The following is a description of a gene set: Genes down-regulated in primary endothelial cells (HUVEC) after knockdown of WTAP by RNAi. from publication Horiuchi K, Umetani M, Minami T, Okayama H, Takada S, Yamamoto M, Aburatani H, Reid PC, Housman DE, Hamakubo T, Kodama T (PMID 17088532) Wilms' tumor 1-associating protein (WTAP) has been reported to be a ubiquitously expressed nuclear protein. Although a relation to splicing factors has been postulated, its actual physiological function still remains to be elucidated. To investigate the role of WTAP, we generated WTAP-knockout mice and performed small interfering RNA (siRNA)-mediated knockdown analyses in primary cultured cells. In DNA microarrays using human umbilical vein endothelial cells, WTAP-targeted siRNA treatment resulted in markedly reduced expression of cell-cycle-related genes. siRNA-mediated WTAP knockdown down-regulated the stability of cyclin A2 mRNA through a nine-nucleotide essential sequence in cyclin A2 mRNA 3' UTR. WTAP knockdown induced G2 accumulation, which is partially rescued by adenoviral overexpression of cyclin A2. Moreover, WTAP-null mice exhibited proliferative failure with death resulting at approximately embryonic day 6.5, an etiology almost identical to cyclin A2-null mice. Collectively, these findings establish WTAP as an essential factor for the stabilization of cyclin A2 mRNA, thereby regulating G2/M cell-cycle transition. studied in species Homo sapiens Human Gene Set: HORIUCHI_WTAP_TARGETS_DN, and this is the list of marker genes: FANCD2, KIF11, SULT1B1, CMPK1, BTBD6, RPL3, NCAPG, PPP1R2, CDC20, ATG9A, IFNAR1, GSPT1, SMAD5, RPL7AP36, BIRC5, CARD11, ATL3, RAD51AP1, CKS1B, COQ3, HMGB2 (NCBI Gene Id 3148), TMSB15A, ATP2C1, PSRC1 (proline and serine rich coiled-coil 1), NEGR1, ZNF618, ARSB, CKS2, CDC27 (NCBI Gene Id 996), SGO2, SYT1, ING3, CCNC, SNRNP27, TMEM123, LSM4, SHMT1, DEPP1, PGRMC2, TMPO, POLD1, LAMP2, RPL22L1, ARL5B, HOOK3, CDH2, SMAD2, NUF2, GSKIP, CAT, WWTR1, RFC5, TIMM50 (translocase of inner mitochondrial membrane 50), RRM2, SEPHS1, ST8SIA4, FBL, ATP8B2, HJURP, DHFR, ANGPT2, NAA15, POLA1, RPRD2, EDEM1, B4GALT6, SPC24, WDFY1, MEDAG, PECAM1, C12orf57, KPNB1, UBXN2A, CDCA8, MAD2L1, KIF4A, NRARP, STON1, PHF10, PAPOLA, TM9SF3, VRK1, ANLN, LMNB2, ESPL1, SNRPA, CKAP2, PLP2, CENPA, H2AX, IPO11, SRPRB, SQLE, CENPW, EBPL, MAP1B, CRIP2, PDE1C, SEPTIN10, PBDC1, RPL7AP10, TPP1, CFAP97, KLHL8 (NCBI Gene Id 57563), PALD1, SC5D, PPM1A, SPATS2L, TMEM106B, PRR11, WTAP, ENY2, LBR, DDX39B (DExD-box helicase 39B), LRRC8C, UHMK1, LRRC17, HMMR, BNIP2, COX7B, AURKA (NCBI Gene Id 8465), LDHB, FDPS, TYMS, TOP2A, STYX, MYBL2, MSTO1 (NCBI Gene Id 55154), HMGCR, STUB1, CEP85, GSR, PIMREG, TMED5 (transmembrane p24 trafficking protein 5), C11orf58, ARHGAP18, NEK2, NCAPD2, AURKB, LRP8, ODC1, PBK, CCNB2, MPP4, CXADR, DLGAP5, TRBC2, H2AZ2, ULBP2, ARL6IP6 (NCBI Gene Id 151188), FLNA, MAGED4B, TRIP13, TWF1, FBXO32, NDC80, RASSF2, LEPROTL1, RRM1, ASPM, PIM3, RAB3B, USP38, DDX11, CD44, CCDC86, CCT7, PGK1, PEX13, TTK, NUP98, CDCA3, SKA3, OIP5 (NCBI Gene Id 123752), BMAL2, DNAJC10, SLC25A5, FASN, PHB1, MTPN, CYTL1, POLR1F, NUSAP1, TOR3A, CXCR4, LMNB1, RPSAP44, C1QBP, MAVS, KIF2C, MBNL1, CNN2, HNRNPA3, PURB, EEF1B2, SPC25, CEP55, UQCC2, MBTPS2, CANX, UNG, UBE2C, DRG2, TMEM245, ASF1A, MGP, BCAP29, ATXN10, CKAP2L, MKI67, DLAT, TMEM97, BUB1B, PRC1, HSP90AA1, PAWR, PPIA, RPL15, BUB3, TDP2, PLK1, APOBEC3B, FOXM1, HELLS, C1D, SNORD60, PAICS, SLC5A3, IMPDH2, HACL1, CCNA2, TK1, DPY19L1, ZDHHC20, NAA50, ANKRD46 (ankyrin repeat domain 46), MCM7, NLN, FUT11, TPX2, CENPM, POLR3G, CDCA2, DEPDC1, MRPL48, UHRF1, PI4K2B, CCNB1, PBRM1, ACAT2, ABCD3, FSD1, CDH5, HMGA2, HMGA1 (NCBI Gene Id 3159), DKK1, KIF18B, ENAH, CHRNA1, NUCKS1, LIN7C, CDKN3, SPAG5, PTTG1, PEG10, AKR1B1, CENPN, GMFB, KIF14, UBE2S, CSK, KIF20A, KNL1, FECH, TROAP, GLS, LDHA, MPRIP, PNRC2, RPL13, LXN (latexin), TMEM33, BUB1, NMT2, ASF1B, DCXR, RACGAP1, ITPRID2, MELK (maternal embryonic leucine zipper kinase), PGF, USP28, RPL13A, H4C3, GLO1, CHST1, KIF22, ARF6, ZNF106, TFB2M, PCLAF, NAP1L1, ATP11C, TRBC1, TSNAX, KIF23, CDC25B (NCBI Gene Id 994), TMEM64 (transmembrane protein 64), RPL7A (ribosomal protein L7a), FAM83D, CDK1, H3-3A, FDFT1, RGS4 (regulator of G protein signaling 4), C21orf91, RNF11, GMNN, GNG10, GTSE1, NDUFA7